Given this list of marker genes DAP, SQSTM1, PIK3R1, TNFRSF1B, MGST3, MT1X, UGT1A10, DNM1, here is a description of the gene set: Human Gene Set: BERENJENO_TRANSFORMED_BY_RHOA_REVERSIBLY_UP We have used microarray technology to identify the transcriptional targets of Rho subfamily guanosine 5'-triphosphate (GTP)ases in NIH3T3 cells. This analysis indicated that murine fibroblasts transformed by these proteins show similar transcriptomal profiles. Functional annotation of the regulated genes indicate that Rho subfamily GTPases target a wide spectrum of functions, although loci encoding proteins linked to proliferation and DNA synthesis/transcription are upregulated preferentially. Rho proteins promote four main networks of interacting proteins nucleated around E2F, c-Jun, c-Myc and p53. Of those, E2F, c-Jun and c-Myc are essential for the maintenance of cell transformation. Inhibition of Rock, one of the main Rho GTPase targets, leads to small changes in the transcriptome of Rho-transformed cells. Rock inhibition decreases c-myc gene expression without affecting the E2F and c-Jun pathways. Loss-of-function studies demonstrate that c-Myc is important for the blockage of cell-contact inhibition rather than for promoting the proliferation of Rho-transformed cells. However, c-Myc overexpression does not bypass the inhibition of cell transformation induced by Rock blockage, indicating that c-Myc is essential, but not sufficient, for Rock-dependent transformation. These results reveal the complexity of the genetic program orchestrated by the Rho subfamily and pinpoint protein networks that mediate different aspects of the malignant phenotype of Rho-transformed cells. studied in species Mus musculus from publication Berenjeno IM, Núñez F, Bustelo XR (PMID 17213802) Genes up-regulated in NIH3T3 cells (fibroblasts) transformed by expression of contitutively active (Q63L) form of RHOA off plasmid vector; their expression reverted completely after treatment with Y27632, an inhibitor of ROCK proteins.